Given this list of marker genes PPP1R2, TIMP1, PDPN (podoplanin), ARL4A, TFPI (NCBI Gene Id 7035), IGFBP5 (insulin like growth factor binding protein 5), FLT4, CD9, SNCG, RARRES2, CLU, GYPC, CISD1, CCL21, TFF3, MAF, PPFIBP1, NR2F2 (NCBI Gene Id 7026), PROX1, APOD, ADD3, PARD6G, FXYD6, FABP5, NRP2, SEMA3A, FN1, LIMS1, RELN, STMN1, CLDN5, IGF1, FABP4, GFUS, CCDC80, EFEMP1, MMRN1, PTPRE, ANGPT2, NR2F1, MRC1, RBP1, NTS, MFAP2, LAPTM5, TSPAN5, RGS16, AKAP12, ADIRF, LYVE1, here is a description of the gene set: In this study, an extensive analysis was conducted to define meta-programs (MPs) capturing intra-tumor heterogeneity across a spectrum of tumor types. The approach utilized non-negative matrix factorization (NMF) to analyze each cell type separately within individual tumor samples. This involved the analysis of malignant cells, macrophages, fibroblasts, endothelial cells, epithelial cells, T-cells, and B-cells. NMF was executed with varying parameter values (K=4, 5, 6, 7, 8, 9), thereby generating 39 programs for each cell type per sample. Each NMF program was summarized by the top genes based on NMF coefficients.\nRobust MPs were then delineated for each cell type using a set of stringent criteria, including recurrence within the same tumor, similarity to programs in other tumors, and non-redundancy within a tumor. Subsequently, these robust NMF programs were clustered (per cell type) based on Jaccard similarity, leading to the identification of MPs associated with each cell type.\nTo enhance the quality of the MPs, a refinement steps were undertaken, involving the removal of MPs suspected of reflecting low-quality data (with an overrepresentation of ribosomal proteins or mitochondrial-encoded genes), single-study inclusion, or similarity to miss-annotated cell types. species: Homo sapiens Human Gene Set: GAVISH_3CA_METAPROGRAM_ENDOTHELIAL_ENDO_2 Genes upregulated in subsets of cells of a given type within various tumors from publication Gavish A, Tyler M, Greenwald AC, Hoefflin R, Simkin D, Tschernichovsky R, Galili Darnell N, Somech E, Barbolin C, Antman T, Kovarsky D, Barrett T, Gonzalez Castro LN, Halder D, Chanoch-Myers R, Laffy J, Mints M, Wider A, Tal R, Spitzer A, Hara T, Raitses-Gurevich M, Stossel C, Golan T, Tirosh A, Suvà ML, Puram SV, Tirosh I (PMID 37258682)